Given this list of marker genes IL7R, STS, LIG4, TWIST2, MRPS22, FLG, TGM1, HLCS, RAG1, DCLRE1C, IL2RG, RAG2, ADA, RMRP, GBA1, CHD7, ALG9, SLC27A4, here is a description of the gene set: species: Homo sapiens Any structural anomaly of the skin of the fetus or newborn. Terms in this subhierarchy are restricted to findings that can only be observed in the prenatal period. Other HPO terms can also be used to describe fetal phenotypes. Human Gene Set: HP_ABNORMAL_FETAL_SKIN_MORPHOLOGY Abnormal fetal skin morphology